The following is a description of a gene set: Reactome Pathway: The canonical retinoid cycle in rods (twilight vision) species: Mus musculus electronically inferred by orthology from the curated human pathway This event has been computationally inferred from an event that has been demonstrated in another species.<p>The inference is based on the homology mapping from PANTHER. Briefly, reactions for which all involved PhysicalEntities (in input, output and catalyst) have a mapped orthologue/paralogue (for complexes at least 75% of components must have a mapping) are inferred to the other species. part of: Visual phototransduction, and this is the list of marker genes: Rdh10, Dhrs9, Myo7a, Rdh5, Rbp4, Rho, Rdh12, Stra6, Hsd17b6, Rbp1, Cyp4v3, Sdr9c7